Given this list of marker genes NRARP, ABCG1, YWHAB, RBBP6, ANK3, CRIPT, ZMYM2, PLAAT3, ARHGAP5, MED13, CNTNAP3B, HGH1, GNG12, FBXO32, HOMER1, TMEM248, ZNF267, SLC30A4, PLCXD2, SLCO1A2, PDE4B, ABCC2, LSM8, USP2, KLLN, MYT1L, PIK3R1, GRAMD1B, PRMT9, EFCAB11, ARNT, CCNT2 (cyclin T2), FAM229B, ARFGEF1, KERA, ENPEP, NAP1L4, MBD5, LSM14A, SGCZ, SIX4, NRIP1, USP34, NFAT5 (nuclear factor of activated T cells 5), BICD2, NFE2L3, CNTN5, MON2, PPHLN1, PHLDB2, HECA, AKAP5, SMC2, MYO5B, SH3GLB1, RORA (NCBI Gene Id 6095), ANKHD1, CNMD, FJX1, TMA16, IL6ST, PDZRN3, RERE, PRRG1, TRDN, TMF1, ZC3HAV1, HMGCR, HDGFL3, CYP4X1, FAM91A1, ZIC1, NPR2, ATP11C, ABCB1, KLHL13, KRIT1, ZNF160, GGCT, GRIN2A, LY75-CD302, SETD9, CFAP20, GXYLT1 (glucoside xylosyltransferase 1), PSD3, RCAN3, GLUL, NKAPL, MACF1, C2orf49, CREB1, CD302, GTPBP2, SMAD4, GUCY1A1, TMEM132A, SLC36A4, INO80D, GSTT2B, RSF1, MAP4K5, PBX1, UBE2N, PTPRQ, PCDH9, ASXL1, EPB41L3, PCDH7, ITGB8, ABCA1, ZNF711, SLC24A1, UBTD2, ABCD3 (ATP binding cassette subfamily D member 3), FBXO25, USP49, KCTD18, CD164, SLC6A4, KMT2C, DNAJC25, ANKRD6, NUP58, SNX13, N4BP2, NDUFB3, EZR, SLIT1, QPCT, CLIC1, CCNG2, TAF1A, GPALPP1 (GPALPP motifs containing 1), SLC7A14, DSTN, ITCH, ABHD5, AEBP2, TRABD2A, SPATA6, MXRA5, MTSS1, DICER1, CCDC180, RNF180 (NCBI Gene Id 285671), ALCAM, SPHKAP, EBF1, MARCHF6, NALF1, SAMD13 (NCBI Gene Id 148418), DLGAP5, ZRANB1, EOGT, UBE2B, TMED7, BRD3, PHTF2, DPH6, DENND1B, UNC119B, CCDC71L, CGGBP1, LIMCH1, PIAS2, DBF4, CANX, PKN2, ZNF616, SRRM1, RCC1, ELMOD2, CCP110, CHMP4C, SLC12A6, PJA2, here is a description of the gene set: species: Homo sapiens Genes predicted to be targets of miRBase v22 microRNA hsa-miR-4778-5p in miRDB v6.0 with MirTarget v4 prediction scores > 80 (high confidence targets). Human Gene Set: MIR4778_5P from publication Chen Y, Wang X (PMID 31504780)